Given this list of marker genes GGA1, EFCAB7, BBIP1, ARL13B, TUB, ARL3, WDR19, ARL13A, RAB29, LZTFL1, IFT80, RABEP1, here is a description of the gene set: studied in species Homo sapiens Human Gene Set: GOBP_PROTEIN_LOCALIZATION_TO_CILIARY_MEMBRANE A process in which a protein is transported to, or maintained in, a location within a ciliary membrane.